The following is a description of a gene set: Genes positively differentially expressed in cell type: γδ T cell upon treatment with cytokine: IL-15 in mouse lymph nodes in vivo. species: Mus musculus from publication Cui A, Huang T, Li S, Ma A, Pérez JL, Sander C, Keskin DB, Wu CJ, Fraenkel E, Hacohen N (PMID 38057668) Mouse Gene Set: CUI_T_CELL_GD_IL15_RESPONSE_UP Cytokines mediate cell-cell communication in the immune system and represent important therapeutic targets. A myriad of studies have highlighted their central role in immune function, yet we lack a global view of the cellular responses of each immune cell type to each cytokine. To address this gap, the authors created the Immune Dictionary, a compendium of single-cell transcriptomic profiles of more than 17 immune cell types in response to each of 86 cytokines (>1,400 cytokine-cell type combinations) in mouse lymph nodes in vivo. A cytokine-centric view of the dictionary revealed that most cytokines induce highly cell-type-specific responses. For example, the inflammatory cytokine interleukin-1β induces distinct gene programmes in almost every cell type. A cell-type-centric view of the dictionary identified more than 66 cytokine-driven cellular polarization states across immune cell types, including previously uncharacterized states such as an interleukin-18-induced polyfunctional natural killer cell state., and this is the list of marker genes: Sub1, Rpn1, Hspa8, U2af1, Igtp, Irf9, Prpf31, Stat1, Znfx1, Utp14a (UTP14A small subunit processome component), Phgdh, Irgm1, Mapkapk2, Mettl1, Ly6a, Stat2, Ifi47, Eif2s1, Ssr2, Cish, Cct5, Smchd1, Ifi209, Ifit3b, Rsad2, Hspa4, Srsf3, Snrpd1, Tuba4a, Il2rb, Atp5pb, Casp8, Trim34a, Nifk, Cfl1, Ddx39b, Snrpa1, Ddx56, Pfkp, Sec13, Pdia3, Bzw2, Kars1, Polr2c, Ddx54, Ldha, Cxcl10, Mybbp1a, Baz1a, Ube2l6, Msn, Ddx21, Ifih1, Hnrnpa3, Larp1, Ifi35, Tor3a (torsin family 3, member A), Hnrnpd, Ifi27l2a, St6galnac4, Shmt2, Mrpl23, Mthfd2, Hspa9, Fbl, Ifit2, Drap1, Gspt1, Nop56, Hspd1, Atp5f1d, Crlf2, Srm, Plaat3, Cd274, Serpina3f, Hectd1, Shisa5, Irgm2, Pa2g4, Isg15, Grpel1, Parp10, Psmb2, Erap1, Nme1, Psmb5 (NCBI Gene Id 19173), Gnl3, Eno1, Dnaja2, Dbnl, Manf, Trafd1, Uqcrb, Cdk6, Cycs, Daxx, Ccdc124, Gbp3, Pdia6, Edf1, Ptges3, Dhx58, Mif, Mrps28, Rtp4, Lsm2, Ffar2, Morf4l2, Slfn1, Psme2, Ppa1, Stip1, Ndufb4, Rigi, Scfd1, Ruvbl1, Eif1ax, Uba1, Ifi204, Npm3, Ndufb7, Tmem167, Gbp4, Isy1, Isg20, Rbm3, Ly6e, Bst2, Tapbpl, Tmbim6, Parp12, Fkbp2, Psmb4, Sec61b, Hspe1, Arhgdia, Psme1, Lgals3bp, Ddx1, Riok1, Cd47, Usp18, Psma4, Cox7a2, Acot7, Atp5mc3, Hnrnpdl, Pkm, Denr, Irf8, Gapdh, Mrpl54, Yrdc, Eif3d, Cndp2, Irf1, Irf2, Sp140, Polr2f, Eif4a3 (NCBI Gene Id 76481), Gbp8, Wars1, Uqcc2, Tmem140, Gbp6, Mars1, Psma2, Rars1, Psmb3, Usp25, Pmepa1, Hsp90ab1, Tubb4b, Selenow, Pfn1, Ptma, Zfp593, Calm1, Nars1, Calr, Adam8, Socs1, Tap2, Il12rb1, Psmg4, Srsf7, Slfn5, Actg1, Cd82, Selenos, Calhm6, Clic4, Herpud1, Prdx1 (peroxiredoxin 1), Chchd2, Arl6ip1, Stat3, Adh5, H2-T23, Eif2s2, Ddost, St13, Eif4a1, Smox (NCBI Gene Id 319808), Hbegf, Dnajb11, C1qbp, Xbp1, Surf4, Ccnd2, Nfkb1, Dgat1, Ndufaf8, Ifi203, Adss1, Atp5f1b, Banf1, Rab5c, Spcs2, Cmpk2, Hsp90aa1, Dkc1, Nmi, Ncl, Notch1, Icam1, Hspa5, Dad1, H2-T22, Ubl4a, Rnf19b, Snrpd3, Ranbp1, Herc6, Aida, F2r, Rab19, Wdr83os, Serpinb9, Smarca4, Nhp2, Utp18, Cysltr2, Ube2l3, Pgd, Igfbp4, Dnajc19, Txn1, Gbp5, Aprt, Llph, Phb1 (NCBI Gene Id 18673), Psma7 (NCBI Gene Id 26444), Pomp, Mrpl12, Oas3, Oasl1, Nudc, Cct3 (chaperonin containing TCP1 subunit 3), Nlrc5, Cxcl9, Mrps12, Parp9, Dtx1, Psmc5, Ifit3, Hint1, Lsm6, Znrd2, Eif1, Trim12c, Gbp2, Mndal, Ndufab1, Ddx39a, Cyba, Iigp1 (interferon inducible GTPase 1), Nsun2, Atp5mc1, Sar1a, Rbm43, Bcl3, Hnrnpab, Hsd17b12, Tap1, Aen, Prmt7, Ybx1, Slirp, Glipr2, Zup1, Ilrun, Ppp1r14b (NCBI Gene Id 18938), Atp2a2, Pebp1, Psmb9, Eif3c, Ppp1r11, Cct2, Sp100 (NCBI Gene Id 20684), Ndufa5, Parp14, Srsf2, Phf11c, Gzmb, Ran, Zbp1, Ascc3, Rsl1d1, Psma3 (proteasome subunit alpha 3), Ctss, Ifi213, Samhd1, Set, Il2ra, Tgtp1, Eif5a, Ostc, Mrpl30, Tbrg1, Slfn2, Iars1 (isoleucyl-tRNA synthetase 1), Cox5a, Sec61g (SEC61 translocon subunit gamma), Ndufa4, Psmb8, Eif2ak2, Txn2, Oasl2, Phf11b, Tars1, Sdf2l1, Hnrnpa1, Pdia4, Trim12a, Nop58, Psmd12, Dnajc2, Bcl2, Rbm8a, Mrpl20, Crem, Ndufa11, Irf7, Lta, Ms4a6b (membrane-spanning 4-domains, subfamily A, member 6B), Mrps34, Asb2, Anp32b, Pus7, Tmed5, Magoh, Pcbp1, Mitd1, Nolc1, Creld2 (NCBI Gene Id 97988), Cnp, Cox7b, Tpm3, Ifitm3, Serbp1, Cacybp, Tmed9, Chmp4b, Wdr18, Dtx3l, Trim25, Lsm4, Psmb7, Oas1a, Eif3b, G3bp1, Cox6a1, Nampt, Ppib, Canx, Hdlbp, Sars1, Bax, Sec11c, Tcp1, Eloc, B2m, Tapbp, H13, Slfn8, Tcof1, Hsp90b1, Ifngr1, Tor1aip2, Npm1, Tbcb, Xaf1, Timm13, Gbp7, Serpina3g, Vars1, Dnajc3, Bcl2a1b, Ifit1, Krtcap2, Castor1, Slc25a5, Gbp9, Ola1, Sp110, Ehd1, Ogfr, Idnk, Capza2, Ndufc1, Ndufa12, Tmed2, Pole4, Ifi27, Ddx24, Cysltr1, Apex1, Ssr4, Samd9l, Aldoa, Psma1, Tuba1b, Snu13, Rnf213, Psma5, Timm8a1, Hmbs, Naa20, Ddx60, Tgtp2, Ncoa7, Capg, Mrto4 (mRNA turnover 4, ribosome maturation factor), Pgk1, Bzw1, Slc35b1, Ankib1, Anp32e (NCBI Gene Id 99603), Ifi206, Jaml, Psmb10, Rexo2, Trim30d, Ebna1bp2, Cct8, Hnrnpf, Ifi208, Odc1, Bag1, Trim30a